Given this list of marker genes CDK15, POTEC, RANBP3L, LUZP1, ZNF691, SORCS3, CDK19, PAX1, ADAMTS17, THBS1, SP1, RGS21 (NCBI Gene Id 431704), KIN, AKAP5, ABRAXAS2, RBM41 (RNA binding motif protein 41), TRAK2, TMEM35A, NRIP3, RAB9A, GPC3, PNISR, ENSA, GBP2, TMEM237, VIPR1, RNLS, TRDN, RAB3IP, NPAT, DAXX, SPRY4, CCDC43, VCAN, TENM1 (NCBI Gene Id 10405), PIN4, LYSMD4, RNF111, FBXW7, DNAJB7, ZBTB5, MRPS33, KRCC1, LRRFIP2, ZNF564, ADAM28, NOL10, LHPP, ANKRD17, SENP6, CPLX2, KATNAL1, PSMG3, SAMD4A, SH3PXD2A, ARPP21, SNF8, NASP, ARFGEF3, BAHD1, ENKUR, AFF1, ZNF618, NABP1, SNAPC4, DCDC1, TNFRSF11A, SLC35D1, NGFR, CPEB4, CACYBP (calcyclin binding protein), TEF, GRM7, NME8, DAG1, FANCG, CPPED1, SP3, HOXA9, FRAS1, MLLT1, NADK2, FAM149A, PRKCB, PRDM13, BRINP1 (BMP/retinoic acid inducible neural specific 1), RAB26, ADAMTS15, NLGN1, USP34, LSM6, ADRA1D, SENP8, ZNF326, FKBP9, ALDH8A1, SLMAP, SESN3, TAF1L, MFSD6L, TRPM8, KCNA5, LIPG, RAB33B, POM121, ARHGEF33, AKT3, CARNMT1, TIMM23, TRIM2, TFE3, TNFSF13B, CCNY (cyclin Y), RAB31, SPRED1, GFI1, KCNA6, UBASH3A, ZBTB8A (zinc finger and BTB domain containing 8A), UBN2, ARHGEF38, MDM4, DBNDD2, SMAD1, KDM3A, FCRL2, TOMM40L, PRKDC, here is a description of the gene set: Human Gene Set: MIR4691_5P species: Homo sapiens from publication Chen Y, Wang X (PMID 31504780) Genes predicted to be targets of miRBase v22 microRNA hsa-miR-4691-5p in miRDB v6.0 with MirTarget v4 prediction scores > 80 (high confidence targets).